Given this list of marker genes Srebf2, Apoc4 (apolipoprotein C-IV), Plin3, Asxl2, Osbpl11, Acacb, Apob, Tmem135, Zc3h12a, Nfkb1, Msr1, Plin2, Ikbke, C3, Nr1h2, Cd36, Pla2g10, Scarb1, Plin5, Vstm2a, Ehd1, Lpl, Hilpda, here is a description of the gene set: species: Mus musculus Any process that increases the rate, frequency or extent of lipid storage. Lipid storage is the accumulation and maintenance in cells or tissues of lipids, compounds soluble in organic solvents but insoluble or sparingly soluble in aqueous solvents. Lipid reserves can be accumulated during early developmental stages for mobilization and utilization at later stages of development. Mouse Gene Set: GOBP_POSITIVE_REGULATION_OF_LIPID_STORAGE